Given this list of marker genes SLC10A1, SLC6A12, SLC10A6, SLC10A4, SLC6A6, SLC5A6, SLC6A1, SLC6A13, SLC10A2, SLC5A12, SLC5A8, SLC6A11, SLC10A5, SLC10A3, SLC6A8, here is a description of the gene set: Human Gene Set: GOMF_MONOCARBOXYLATE_SODIUM_SYMPORTER_ACTIVITY Enables the transfer of a solute or solutes from one side of a membrane to the other according to the reaction: monocarboxylate(out) + Na+(out) = monocarboxylate(in) + Na+(in). studied in species Homo sapiens